The following is a description of a gene set: GPER1 signaling studied in species Mus musculus Mouse Gene Set: REACTOME_GPER1_SIGNALING, and this is the list of marker genes: Prkaca, Gper1, Gng4, Gnb4, Gnas, Gng2, Gng10, Itga5, Gng11, Gng13, Gng12, Gnb3, Prkacb, Gng7, Prkar1b, Gngt2, Itgb1, Prkar1a, Gnb2, Shc1, Gng3, Gnb5, Gng5, Gng8, Fn1, Gngt1, Gnb1